The following is a description of a gene set: Any process involved in the maintenance of an internal steady state of ubiquitin monomers and free ubiquitin chains at the level of the cell by recycling ubiquitin from proteasome-bound ubiquitinated intermediates. studied in species Homo sapiens Human Gene Set: GOBP_UBIQUITIN_RECYCLING, and this is the list of marker genes: AMBRA1, ELP6, UBE2K, RNF135, TRIM32, VPS54, PLAA, UBE2S, IDE, PINK1, FBXW7, TRIM6, UBE2C, PRKN